The following is a description of a gene set: species: Homo sapiens The process in which genetic material, in the form of chromosomes, is organized into specific structures and then physically separated and apportioned to two or more sets. In eukaryotes, chromosome segregation begins with the condensation of chromosomes, includes chromosome separation, and ends when chromosomes have completed movement to the spindle poles. Human Gene Set: GOBP_CHROMOSOME_SEGREGATION, and this is the list of marker genes: PTTG2, CCDC69, BAZ1B, NCAPD2, CENPX, AURKA, SMC5, MAPRE3, CCNB1, CDCA5, RACGAP1, ESCO2, CENPQ, VPS4A, TUBGCP2, PPP2R2D, KLHDC8B, KIF18B, HAUS1, TRIP13, KNSTRN (kinetochore localized astrin (SPAG5) binding protein), TUBGCP3, MAD2L2, TOP1, NCAPG, SETDB2, CENPO, MAD2L1BP, FAM83D, SGO2, BEX4, DCTN2, PPP2R1B, HECW2, NUP43, KIF4B, CCSAP, TTL, MAPRE2, TLK1, HAUS5, HASPIN, HAUS7, SPICE1, CEP97, XRCC3, NR3C1, AKAP8, CDC27, DPF1, UHRF1, CCDC61, FBXO30, MAPRE1, CDC42, CIAO1, PPP2R2A, SKA1, CENPH, CLASP2, CDC20, SPAG5 (sperm associated antigen 5), DPF2, TEX14, KIF3B, RHOA, MAGEA5P, SMC6, C9orf78, MKI67 (marker of proliferation Ki-67), TEX12, UVRAG, P3H4, DDX3X (DEAD-box helicase 3 X-linked), OFD1, MSH5, UBE2C, SMC4, ABRAXAS1, M1AP, RB1, CHMP1B, ANAPC2, CEP85, KIF2A, CENATAC, RGS14, C14orf39, RIOK3 (NCBI Gene Id 8780), MAU2, CENPS, CSNK1D, MAEL, GTF2B, TEX11, TOP3A, TRAPPC12, NDC1, PUM2, DYNC1LI1 (dynein cytoplasmic 1 light intermediate chain 1), NCAPG2, KIF2B, CENPE, SUN1, MRE11, DLGAP5, KIF15, SASS6, OIP5, RMDN1, NUP62, CEP55, NDEL1, RECQL5, SPDYA, CHFR, INCENP, SAC3D1, PPP2R1A, KNTC1 (kinetochore associated 1), NEK2, RAB11A, NUDC, HJURP, DPF3, CDC23, ARHGEF10, KMT5A, C1orf146, DDB1 (damage specific DNA binding protein 1), CSNK2A1, MIS18A, NDE1, ARID1A, IK, RAD21L1, CHMP4BP1, ANKRD31, NAA60, RANGRF, CSNK2A2, SMARCE1, ANAPC15, HDAC3, CENPN, TERB1, NUP37, ARID2, PTTG3P, KIF2C, SEH1L, MAP9, PRDM9, MLH3, PPP1CC, APC, KIF25, TUBG1, SMARCC1, SHOC1, PDCD6IP, CEP63, TUBGCP5, RNF4, SMARCD2, DUSP1, CENPK, ACTL6B, SGO1, BCL7B, TENT4A, MZT1, FIRRM, HSPA1B, NSL1, RCC2, KAT2B, EML3, MTCL2, USP44, CENPP (NCBI Gene Id 401541, centromere protein P), TUBGCP4, LATS1, SPC24, UBE2B, AAAS, SKA3, RCC1, PLK1, TOP2B, CDT1, HAUS3 (HAUS augmin like complex subunit 3), DRG1, CENPW, SMARCAD1, CHMP2A, RIOK2, MMS19, SIRT2, RMI2, ESPL1, RAB24, NSMCE2, MTCL1, BUB1B, MISP, RAN, SYCP2, ZCWPW1, RNF212, CCNB1IP1, BECN1, DIAPH3, BUB3, SMARCA5, HAUS4, GOLGA2, ZW10, CENPF, AURKB, ACTL6A, KIF14, EML4, CENPM, WAPL, UBE2I, ANAPC1 (NCBI Gene Id 64682), MAP3K20, HAUS2, TERF1, NUF2, DYNC1H1, TPX2, MAJIN, KNL1, SMARCD3, STIL, SENP6, ANAPC5 (anaphase promoting complex subunit 5), GPSM2, MAD1L1, LZTS2, SMARCA2, CIAO2A, ARL8B, ABRAXAS2, BRCA1, NTMT1, CCNE2, ACTR2, ERCC2, CENPU, LCMT1, CHAMP1, EHMT2, KIFC1, LSM14A, TERB2, SMARCD1, KATNB1, TUBGCP6, MYBL2, HSPA1A, MND1, NIPBL, ANAPC11, IHO1, KIF23, CCNE1, KAT5, PHF10, H2BW1, KIF11, TNKS, SMARCC2, CTCF, PRP4K, AURKC, MEIKIN, MOS, REC8, CUL3, KLHL22, SEPTIN1, WRAP73, MEI4, FBXO5, DIS3L2, CHMP4B, CCNB2, CENPI, CDCA2, CDK1, SPATA22, BAG6, FMN2, TPR, ANKRD53, TOP2A, TUBB1, CENPL, CEP192, RAD18, WASHC5, STAG1, NDC80, PRC1, RRS1, PINX1, ASPM, PIBF1, PRICKLE1, SMARCA4, DMC1 (NCBI Gene Id 11144), VPS4B, AKAP8L, SMC3, MAP1S, SLC25A5, ACTR3, CHMP1A, ZWINT, SMC2, KIF4A, CHMP6, MLH1, SYCE1L, SYCE1, SPC25, MEIOB, CDCA8, SPDL1, INO80, CDC16, BUB1, ENSG00000266560, CHMP4C, CENPT, FANCD2, RIPOR2 (NCBI Gene Id 9750), CDC6, RPS3, USP9X, CHMP7, PRAP1, HORMAD1, BCCIP, CCDC66, SMARCB1, MAD2L1, BCL7C, RNF212B, CENPJ, ECT2, POLDIP2 (DNA polymerase delta interacting protein 2), HAUS8, NCAPH2, DCAF13, SKA2, CHMP2B, CHEK2, SYCE2, GEM, SRPK1, ARL8A, KASH5, ACTB, NUSAP1, TOP3B (DNA topoisomerase III beta), BIRC5, CHMP5, TUBB, MEIOC, CIAO2B, STAG3, CDK5RAP2, MAP10, RAD21, STAG2, TLK2, PSRC1, SIRT1, TTK, BRD7, HAUS6, MCMDC2, ANAPC7, NEK7, TUBB8, FLNA, HNRNPU, GEN1, PTTG1 (PTTG1 regulator of sister chromatid separation, securin), PLSCR1, PHF13, PSMC3IP, SYCP1, BOD1, PBRM1, PMF1, NUMA1, PTEN, MSH4, NCAPD3, ARID1B, CHMP3, STARD9, BRIP1, BCL7A, TTN, CHMP4A, SIRT7, KIF22, ANAPC4, KPNB1, MIS12, KIF18A, DSN1, TACC3, BCAS2, PSMG2, MAPK15, SMC1A, SYCE3, SPO11, TUBG2, NEK6, AGO4, NCOR1, ZWILCH, CENPC, CLASP1, PUM1, TEX15, NCAPH, ZNF207, ITGB3BP, ATM